Given this list of marker genes CLTC, GAK, HSPA8, DNAJC6, SYNJ1, VPS4A, here is a description of the gene set: A protein depolymerization process that results in the disassembly of vesicle coat proteins. Human Gene Set: GOBP_VESICLE_UNCOATING studied in species Homo sapiens